The following is a description of a gene set: studied in species Homo sapiens Human Gene Set: REACTOME_PYROPTOSIS Pyroptosis, and this is the list of marker genes: ELANE, IL1A, GZMB, IRF2, GSDMD (NCBI Gene Id 79792), CHMP2B, CYCS, CHMP4A, IL1B, CASP5, IRF1, CHMP4C, CHMP2A, CHMP3, IL18, CASP4, GSDME, BAK1, HMGB1, CHMP6, CASP1, TP63, CHMP4B, CHMP7, CASP3, BAX (BCL2 associated X, apoptosis regulator), TP53